Given this list of marker genes Psg17, Xirp1, Pmm2, Prss32, Arhgef2, Plpp6, Cd37, Khnyn, Dtna, Cdsn, Ptp4a1, Igf2bp2 (NCBI Gene Id 319765), Cyp2c55, Krtap4-6, Phc2, Mbnl3, Sftpa1, Gria2, Atxn1l, Krtap4-2 (keratin associated protein 4-2), Trp53inp2, Iqsec3, Fbxw9, Pklr, Gars1, Ttc9, St8sia6, Xylt2, Psca, Tcte1, Psd3, Psg22, Me3, Fcgr1, C2cd2l, Atf6, Zfhx3, Dlg4, Slc26a5, Tnfsf13, Fam89b, Gpr149, Trnp1, Stk35, Marf1, Slco1a5, Ppp4c, Wnt1, Adcyap1r1, Nr6a1, Wars1, Ldb3, Atg10, Ezh1, Cbx7, Psg26, Htra3, Ap1g1, Dnajb13, Trpc3, Grb10, Bptf, Cry2, Hpcal4, Psg21, Acer2, Vps25, Tnfsfm13, Parp11, Dagla, Psg19, Scn4b, Cdk6, St8sia3, Eya1, Cntn4, Sfmbt2, Hnrnpu, Fev (NCBI Gene Id 260298), Zmiz1, Gm867, Brpf3, Bbln, Cyp4v3, here is a description of the gene set: Genes predicted to be targets of miRBase v22 microRNA mmu_miR_705 in miRDB v6.0 with MirTarget v4 prediction scores > 80 (high confidence targets). from publication Chen Y, Wang X (PMID 31504780) species: Mus musculus Mouse Gene Set: MIR_705